The following is a description of a gene set: Any process that modulates the frequency, rate or extent of fibrinolysis, an ongoing process that solubilizes fibrin, resulting in the removal of small blood clots. species: Mus musculus Mouse Gene Set: GOBP_REGULATION_OF_FIBRINOLYSIS, and this is the list of marker genes: Hrg, Plaur (NCBI Gene Id 18793), Serpine1, Plat, Thbs1, F12, F11, Plau, Klkb1, Serpinf2, Plg, Vtn, Cpb2, Apoh (apolipoprotein H)